The following is a description of a gene set: Mouse Gene Set: GOBP_REGULATION_OF_CAMP_PKA_SIGNAL_TRANSDUCTION Any process that modulates the frequency, rate or extent of cAMP/PKA signal transduction. studied in species Mus musculus, and this is the list of marker genes: Crh, Calcr, Adrb2 (NCBI Gene Id 269028), Adgrv1, Sesn2, Grin2b, Iapp, Spatc1l, Pde10a, Pkia, Prkar2a, Rps23rg1, Gpr3, Gip, Mif, Mc1r, Lrrk2, Prkar1a, Ramp3, Pde3a, Pde4a, Prkar1b, Adipoq, Ucn, Lpar1, Prkar2b, Adcyap1